Given this list of marker genes CA6, CA2, CA14, CA7, CA12 (NCBI Gene Id 771), CA11, CA8, CA5B, CA9, CA1, CA3, CA5A (carbonic anhydrase 5A), CA5BP1, CA13, CA4, CA10, here is a description of the gene set: Human Gene Set: GOMF_CARBONATE_DEHYDRATASE_ACTIVITY studied in species Homo sapiens Catalysis of the reaction: hydrogencarbonate + H+ = CO2 + H2O.